Given this list of marker genes IKBKB, MIR24-1, TNFRSF19, FOXO3, TNFRSF17, H2BC11, RFFL, RIPK1, MAPK14, MIR27B, NOL3, SYK, CARD16, MIR21, LIMS1, NR1H4, KRT18, UBE2K, TXNDC17, JAK2, NFKBIA, MIR152, DICER1, NAIP, MIB2, TNFRSF13C, CDK5R1, ADAM10, TNFRSF18, PYDC2, CYLD, EIF5A, ULK1, CASP4, COMMD7, TNFRSF4, NRDC, ADIPOQ, PTK2B, BIRC2, SPHK1, TRAF3, TNFSF13B, NR2C2, EDA2R, BIRC7, CCDC3 (NCBI Gene Id 83643), OTULIN, TNFSF11, ACTN4, NKIRAS1, CHUK, ANXA4, KRT8, TMSB4X, CASP1, EXT1, NSMAF, TRAF5, PIAS4, APOA1, BIRC3, TNFRSF14, PLVAP, PELI3, TRAF1, TANK, PYCARD, TRAF6, SPPL2B, CPNE1, CARD14, MIR1246 (microRNA 1246), PRKN, PYDC1, HSPA1B, DAB2IP, CASP8, CD70, HIPK1, MIR34A, SPATA2, TRADD, TRAF3IP2, CLDN18, TNFRSF11B, UMOD, ZNF675, MMP8, MIR125B1, MAPKAPK2, GAS6, AIM2, XIAP, STAT1, GSTP1, LAPTM5, TRAIP, TNFRSF1A (TNF receptor superfamily member 1A), SPPL2A, TNFRSF11A, FAS, CARD8, TNFSF18, NKIRAS2, TNFRSF25, HSPA1A, F2RL1, NLRP2B, PPP2CB, PTPN2, TAX1BP1, TNF, PIAS3, MIR130A, GPS2, TP53, RRAGA (NCBI Gene Id 115960), TRAF2, TIFA, NFKB1, RELA, TMC8, TNFAIP3, ILK, TRIM32, TNFRSF1B, SHARPIN, ADAM17 (ADAM metallopeptidase domain 17), ST18, here is a description of the gene set: The series of molecular signals initiated by tumor necrosis factor binding to its receptor on the surface of a cell, and ending with the regulation of a downstream cellular process, e.g. transcription. studied in species Homo sapiens Human Gene Set: GOBP_TUMOR_NECROSIS_FACTOR_MEDIATED_SIGNALING_PATHWAY